Given this list of marker genes FERMT3, RAP1A, MIR21, CCR7, YWHAQ, FYB1, LPL, FOXO1, MOB1A, SAV1, WWTR1, NDRG1, STK3, RAC1, TEAD4, MAPK14, MST1, FOXO6, TEAD1, TEAD3, FOXO4, RAB13, RASSF5, KNSTRN, PRDM1, CD19, ITGAL (NCBI Gene Id 3683), LATS2, YAP1, FOXP3, RHOA, LATS1, FOXO3, TEAD2, STK38L, here is a description of the gene set: Leukocyte-intrinsic Hippo pathway functions Human Gene Set: WP_LEUKOCYTEINTRINSIC_HIPPO_PATHWAY_FUNCTIONS studied in species Homo sapiens